Given this list of marker genes SLC6A14, here is a description of the gene set: Reactome Pathway: Variant SLC6A14 may confer susceptibility towards obesity SLC6A14 mediates the uptake of multiple basic and nonpolar amino acids as well as beta-alanine across the plasma membrane. Uptake of one amino acid molecule is accompanied by uptake of two sodium ions and a chloride ion (Broer & Gether 2012, Schweikhard & Ziegler 2012). As assessed by Northern blotting, SLC6A14 is expressed at high levels in lung but only at low levels, if at all, in intestine or kidney. Variations in SLC6A14 may be associated with obesity (BMIQ11; MIM:300306) in some populations. SLC6A14 is an interesting candidate for obesity because it may potentially regulate tryptophan availability for serotonin synthesis and thus could affect appetite control. species: Homo sapiens part of: SLC transporter disorders